The following is a description of a gene set: species: Mus musculus A protein ubiquitination process in which a polymer of ubiquitin, formed by linkages between lysine residues at position 27 of the ubiquitin monomers, is added to a protein. Mouse Gene Set: GOBP_PROTEIN_K27_LINKED_UBIQUITINATION, and this is the list of marker genes: Ube2t, Trim62, Rnf6, Amfr, Rnf185, Rnf126, Ube2s, Trim21, Ube2srt, Ube2d2b, Ubr4, Wsb1